The following is a description of a gene set: species: Mus musculus Generation of a long process from a neuron whose cell body resides in the central nervous system. The process carries efferent (outgoing) action potentials from the cell body towards target cells. Mouse Gene Set: GOBP_CENTRAL_NERVOUS_SYSTEM_NEURON_AXONOGENESIS, and this is the list of marker genes: Nr2e1, Grcc10, Draxin (NCBI Gene Id 70433), Chrnb2, Kifbp, Ndel1, B4galt5, Slit2, Fbxo45, Prdm8, Cdh11, Pafah1b1, Tsku, Bhlhe22, Atg7, Gli2, Dcc, Szt2, Arhgef28, Prkca, Sptbn4, Tctn1, Dclk1, Dcx, Spg11 (NCBI Gene Id 98786), Nin, Phox2b, Nfib, Mycbp2, Zeb2, Ephb1, Adarb1, Dubr, B4galt6, Nr4a2, Pten, Ephb2, Epha4, Ephb3, Scn1b, Plxna4, Arhgap35, Wdr47, Ptk2